The following is a description of a gene set: from publication Wallace TA, Prueitt RL, Yi M, Howe TM, Gillespie JW, Yfantis HG, Stephens RM, Caporaso NE, Loffredo CA, Ambs S (PMID 18245496) The incidence and mortality rates of prostate cancer are significantly higher in African-American men when compared with European-American men. We tested the hypothesis that differences in tumor biology contribute to this survival health disparity. Using microarray technology, we obtained gene expression profiles of primary prostate tumors resected from 33 African-American and 36 European-American patients. These tumors were matched on clinical variables. We also evaluated 18 nontumor prostate tissues from seven African-American and 11 European-American patients. The resulting datasets were analyzed for expression differences on the gene and pathway level comparing African-American with European-American patients. Our analysis revealed a significant number of genes, e.g., 162 transcripts at a false-discovery rate of <or=5% to be differently expressed between African-American and European-American patients. Using a disease association analysis, we identified a common relationship of these transcripts with autoimmunity and inflammation. These findings were corroborated on the pathway level with numerous differently expressed genes clustering in immune response, stress response, cytokine signaling, and chemotaxis pathways. Several known metastasis-promoting genes, including autocrine mobility factor receptor, chemokine (C-X-C motif) receptor 4, and matrix metalloproteinase 9, were more highly expressed in tumors from African-Americans than European-Americans. Furthermore, a two-gene tumor signature that accurately differentiated between African-American and European-American patients was identified. This finding was confirmed in a blinded analysis of a second sample set. In conclusion, the gene expression profiles of prostate tumors indicate prominent differences in tumor immunobiology between African-American and European-American men. The profiles portray the existence of a distinct tumor microenvironment in these two patient groups. Human Gene Set: WALLACE_PROSTATE_CANCER_DN Genes down-regulated in prostate tumor vs normal tissue samples. studied in species Homo sapiens, and this is the list of marker genes: GPM6B, LAMA4, AKAP12, GJA1, RAP1B, CAV2